The following is a description of a gene set: Human Gene Set: BUSSLINGER_DUODENAL_DIFFERENTIATING_STEM_CELLS from publication Busslinger GA, Weusten BLA, Bogte A, Begthel H, Brosens LAA, Clevers H (PMID 33691112) species: Homo sapiens, and this is the list of marker genes: EPHB2, AQP1, EIF3L, HSP90AA1, MAOA, PABPC1, RPLP1, EIF3E, SRP9 (NCBI Gene Id 6726), RAN, HSPA8, RPL29, TSPAN8, SNRPF, PTGES3, RPL35, REG1A, MTHFD1, RPL38, RPLP0, SNHG5, GPX2, HNRNPA2B1, RPS3, RPL8, RPS20, RPL30, RPS27, HMGB2, HSP90B1, RPS15, MT1E, MT1G, PIGR, DBI, ALDH2, ATP5MF, IDH2, SOD1, NFIB, RPL19, EIF3K, RPL11, NUCKS1, MCM7, RPL39, MT2A, RPL37A, SNHG16, RPL14, RPL7, TMA7, EI24, CPS1, RPS2, SERBP1, TKT (NCBI Gene Id 7086), ELAPOR1, RPS6, TOMM40 (NCBI Gene Id 10452), TM9SF3, MGST1, NRARP, COX7B, HMGA1 (high mobility group AT-hook 1), ENO1, RPS14, SPINK1, RPS11, RPL18, AHCY, MDH2, SUCLG1, EIF1AX, RPL23, RPL6, COX5B (NCBI Gene Id 1329), CDCA7, TMPO, PRKDC, HNRNPU, KPNB1, HINT1, RPL27A, HSPD1, ATP5MC1, EIF5B, TXN, SFPQ, RPS27A, DMBT1, ASPM, PAICS, TFRC, TUBB, DDX21, TRIM28, MT1X, RPL18A, COX4I1, CD9, ATP5IF1, EMP2, PTMA, OLFM4, CLDN3, DHFR, NASP, EIF2S3, YBX1, NDUFB9, LRPPRC, EEF1B2, RPL35A, RPS9, SLC12A2, RPS3A, YWHAB, LBR, XRCC5, HMGCS2, PPIF, SLC25A5, MACROH2A1, ARL6IP1, ATP5PB, CALM2, H4C3, RPL15, RPL41, LGALS4, RPL27, RPL26, PLP2, CYC1, NPM1, CCT5, CS, RPL24, HNRNPAB, RPS5, COX8A, RPL13, RPS28, DDAH1, AGR2, ATP5PO, ACTG1, RPS15A, PCLAF, NONO, ECH1, CCT2, BHLHE40, VDAC1, RPS19, PPP1R1B, PHB2, ATP5MC3, BTF3, ADH1C, COX7C, NCL, KCNE3, DUT, RPS7, COX7A2, NDUFA4, HSPE1, KRT19, RPS24, BANF1, PDLIM1, CCL25, CBX3, UQCRFS1, EEF1G, RPL4 (ribosomal protein L4), TUFM, FBL, MLEC, RPL12, HNRNPC, IMPDH2, RBM3, CKS2, STMN1, EEF1A1, SMC4, RPL13A, TUBA1B, SOX4, RPL9, SRSF2, SLIRP, RPS8, RPL10A, MT1F, RCC2, MKI67, HNRNPD, HADH, CCT6A, EGR1, RPLP2, ADD3, SNRPE, RPL7A, ALDH1A1, RPL31, PRDX3, NOP56, APEX1, PCNA, RPL10 (ribosomal protein L10), NOP58, RPL3, RPL34, RPS16, RPS13, GSTP1, RPL32, DEK, UQCRQ, TOP2A, HMGN1, RPS23, RPS12, RACK1, RPL5, EIF4B, RPS4X, RPS25, YWHAZ, CLIC1, CLU, SERF2, NDUFAB1, ZFAS1, RPL28, KRT18, YWHAQ, ANP32B, LSM4, RPL17 (ribosomal protein L17), TMSB10, ATP5PD, NDUFS5, COX6C, HNRNPM (NCBI Gene Id 4670), PPIA, SNRPB, GAS5, ONECUT2, EEF2, RPL37, H2AZ1, APP, RPS18, HSP90AB1, PKM (pyruvate kinase M1/2), SET, HNRNPK, CANX, GOLM1, C9orf152, SLC25A3, ATP5F1B, CDC42EP5, ATP5MC2, ILF3, ATP5F1A, GAPDH, ESD, KLF5, COX5A, RPL22, CENPF, HNRNPA1, RPL36, CYCS, SNHG29, EIF3A, PFN1, EPCAM, LAD1, KRT8, SF3B5, CHCHD2, HMGB1, HNRNPR, RPS29, COX6A1 (NCBI Gene Id 1337), FAU, CCND2, RRM2, SNHG6, MARCKS, ANXA2, SRSF3, SRSF1, FAM120A, SNHG8, C1QBP, VDR